Given this list of marker genes Slamf8, Grn, S100a9, Ncf1, Ins1, Ins2, Lbp, Rps19, Dusp10, here is a description of the gene set: Any process that modulates the rate, frequency or extent of a phase of elevated metabolic activity, during which oxygen consumption increases made as a defense response; this leads to the production, by an NADH dependent system, of hydrogen peroxide (H2O2), superoxide anions and hydroxyl radicals. Mouse Gene Set: GOBP_REGULATION_OF_RESPIRATORY_BURST_INVOLVED_IN_INFLAMMATORY_RESPONSE studied in species Mus musculus